The following is a description of a gene set: studied in species Mus musculus Mouse Gene Set: MIR_7061_5P Genes predicted to be targets of miRBase v22 microRNA mmu_miR_7061_5p in miRDB v6.0 with MirTarget v4 prediction scores > 80 (high confidence targets). from publication Chen Y, Wang X (PMID 31504780), and this is the list of marker genes: Spire1, Clint1, Filip1l (NCBI Gene Id 78749), Ulk3, Glyr1, Sec61g, Sco1, Fabp7, Ott, Slc6a8, Zic1, Prkaa1, Fnbp1l, Atxn3 (NCBI Gene Id 76702), Cntnap5b, Acsl4, Lrfn2, Wdr26, Sirt1, Nedd4l, Oaz2, Zfp385b (NCBI Gene Id 319834), Zfand6, Atp2b2, Ildr2, Phyhipl, Nsd3, Tmem150b, Ap1s3, Mpc1, Slc8a1, Sema6d, Mbnl3, Acss3, Hsdl2, Cand1, Ccar2, Casp2, Camk1, Kpna1, Papola, Nsmce2, Kcnip4, Ccdc125, Alox5ap, Senp2, Trpc4, Cyp3a13, Arhgap12, Ccdc126, Mplkip, Csnk2a2, Sorcs1, Ddx27, Ubr2, S1pr3, Kalrn, Ptgfr, Fhl1, Sult1d1, Tmx4, Homer1, Scn5a, Setd5, Lrrc39, Steap2, Usp3, Rbm46, Lhfpl2, Ptp4a1, Glud1, Kctd18, Apbb2, Nrg3, Ino80d, Herc4, Naa30, Lin7a, Hoxa10, Otc, Rab33a, Ywhaq, Nfyc, Trappc6b, Slc30a9, Cecr2, Ctcf, Nhlh2, Gng4, Or7d10, Trappc3, Mysm1, Glis3, Ube2v2, Tlcd4, Hs3st5, Pofut2, Dynlt1b, Nudcd1, Inpp5a, Stam2, Clec1a, Map4, Inpp5e (NCBI Gene Id 64436), Nudt10, Vav3, Hapstr1, Cct2, Zfp292, Smim14, Cggbp1, Atp2b4, Rabgap1l, Wapl, Vps26a, Arrdc3, Morc2a, Epc2, Jcad, Jak2, Slc25a30, Gm15107, Trpc1, Map1b, Lmod1, Lyset, Atp11c, Slc44a5, Rsbn1l, Lrp12, Zfyve28, Myh10, Ccdc88a (coiled coil domain containing 88A), Lrat, Arhgap28, Abca1, Fcho2, Slc5a8, Bag5, Tnks2, Smarca2, Rbpj, Il1rap, Atxn1, Foxf1, Usp13, Prkd3, Atrx, Sgpp1, Slc2a12, Car8, Col19a1, Ndn, Klf10, Ppp1r18, Ranbp9, Gnpda2, Tmem65, Nus1, Eif4e3, Hnrnpk, Cxxc4, Nlrp4a, Gm15080, Aunip, 4931414P19Rik, Gm15097, Fam76a, Nufip1, Pln, Cdh11 (cadherin 11), Kcne4 (potassium voltage-gated channel, Isk-related subfamily, gene 4), Adam22, Gm15114, Adamts17 (NCBI Gene Id 767813), Ttc14, Heph, Vapb, Prrc2c, Caprin2, Hmgcll1, Ldb2, Jmjd1c, Ptger4, Tnfrsf11a, Rac1, Tmem168, Cnot6l, Gabra1, Ube2d2a, Scai, Lemd3, Myo1d, Skil, Nphp3, G3bp2, Rasgef1b (NCBI Gene Id 320292), Afp, Rora, Kras, Itgb1, Supt7l, Gnb2, Grm4, Orc1, Yif1a, Plxna3 (NCBI Gene Id 18846), Cyb561d1, Trmt10a, Tsc22d2, Gm15091, Tbc1d25, Atp10b, Nhsl2, Gm15093, Ube2d1, Gpr88, Aff3, Tnrc6b, Ikzf2, Gm15127, Nipa2, Pard3, Rgs17, Or10d5j, Dclk1, Tenm3, Sh3bgrl2, Gria2, Sowaha, Selenop, Tmem11, Dhx35, Nsl1, Exoc5, Pbx1, Spart, Nudt11, Pdcd6, Fhad1, Phf5a, Nr6a1, Fam13c, Plxdc2 (NCBI Gene Id 99276), Syt6, Grk1, Tmem18, Igf1, Slc4a4, Chic1, Tmtc1, Slc23a2, Septin7, Abi1, Trim27, Cckar, Gm15085, Urgcp, Clec14a